Given this list of marker genes Gtf2a1, Gpr137b, Usp42, Zfp386, Meig1, Tfdp1, Tnfsf9, Cd160, 5730455P16Rik, Tmigd1, Akr1c14, Esp16, Enpep, Ark2n, Zfp268, Ccdc153 (NCBI Gene Id 270150), Dlgap1 (DLG associated protein 1), Prcp, Ivns1abp, Ccng2, Slc39a8, Lox, Odr4, Scart1, Rftn2, Esp18, Kctd5, Elavl2, Rerg, Pkd2, Hccs, Sema6a, Vps4b (NCBI Gene Id 319619), Hbp1, Akr1c6, Mob4, Septin7, 1810037I17Rik, Ppp2cb, Ehd4, Smoc2, Kdelr3, Per3, Slc38a2, Canx, Tmem81, Zdhhc17, Stx18, Stradb, Sult3a1, Tom1l1, Ptprj, Dmrta1, Sema4g, Myef2, Ifi207, Esp15, Zfp59, Cbfb, Iah1, Zfp37, Adgrf5, Ndst2, Erc1, Clmp, Plcb1, Cyp2c50, Mbtd1, Ywhaq, Cdk6, Pum2, Clasp2, Btbd16, Fbxl2, Sspn, Sec16a, here is a description of the gene set: Mouse Gene Set: MIR_3068_3P species: Mus musculus Genes predicted to be targets of miRBase v22 microRNA mmu_miR_3068_3p in miRDB v6.0 with MirTarget v4 prediction scores > 80 (high confidence targets). from publication Chen Y, Wang X (PMID 31504780)